The following is a description of a gene set: Acute phase response Human Gene Set: HP_ACUTE_PHASE_RESPONSE species: Homo sapiens Presence of one or more manifestations of the acute phase response. Acute phase proteins (APP) are blood proteins primarily synthesized by hepatocytes as part of the acute phase response (APR). The APR is part of the early-defense or innate immune system, which is triggered by different stimuli including trauma, infection, stress, neoplasia, and inflammation. The APR results in a complex systemic reaction with the goal of reestablishing homeostasis and promoting healing., and this is the list of marker genes: PRKAR1A, SCARB2, SPINK1, VHL, CYP27B1, RNU4ATAC, PTPN2, IFT56, LIN28B, TREX1, SEC61A1 (SEC61 translocon subunit alpha 1), GBA1, SLC34A3, AIRE, LMNA, PTPN6, TBCE, FAS, GCM2, UBA1, LACC1, PLCG1, BMP6, CCR1, TGFB1, IL6, IL2RA, MEFV, UMOD, SLC4A1, SLC7A7, LMO1, C4A, CARD10, CTLA4, ANKRD55, IRAK1, ADORA2A, FH, SLC40A1, PHOX2B, IFIH1, ADA2, SH2D1A, TMPRSS6, CP, SLC25A38, CYP24A1, CDC73, IL1R1, MAX, P4HA2, PIEZO1 (piezo type mechanosensitive ion channel component 1 (Er blood group)), STAT2, HLA-DPA1, NFKBIL1, PSMB9, IL12A, CASP10, HFE, TRAF3, RNF31, LBR, MYD88, COPA, STX16, ITK, TLR4, CTRC, LYN, TBX1, TBK1, TLR3, PDE4D, MPV17, PSMB10, PTPN22, SLC22A4, KIF1B, LPIN2, IFNGR1 (NCBI Gene Id 3459), CFTR, SAT1, SLC29A3, RET, KARS1, STXBP2, TMEM127, TNFRSF1A, UNC93B1, PTH, CDKN2C, KLRC4, HLA-DRB1, FOCAD, IL2RB (interleukin 2 receptor subunit beta), SLC19A1, KL, CD244, BCS1L, PIGA, ERAP1, CIITA, SHARPIN, ALK, PRTN3, STEAP3, SDHAF2, MIF (macrophage migration inhibitory factor), IL12A-AS1, KCNN4, NCF4, PRSS1, GNAS-AS1, MLX, MIR140, STAB1, IL36RN, STING1, OCRL, FTH1, PSTPIP1, GNAS, FTL, SDHD, CDKN2B, TFR2 (transferrin receptor 2), VDR, C1QB, ARPC5, ITGB2, AP1S3, NOD2, PRF1, HMOX1, NF1, SDHA, HBB, LYST, SYK, ARPC1B, HAMP, SPP1, CASR, MVK, FAM20A, OTULIN, IL12B, XIAP, PHEX, CLDN16, PIK3CG, NLRP12, HAVCR2, DLST, CDKN1A, POMP, PUS1, CYP2R1, UBAC2, STX11, IFNG, CMPK2, IL6ST, IL37, PSMB4, NLRP3, CDKN1B, PRG4, SLC34A1, SDHB (NCBI Gene Id 96200), MEN1, CPOX, C2orf69, CPA1, UNC13D, HJV, SAMD9, ZNFX1, SLC25A11, NLRC4, TRPV6, GLRX5, HLA-B, CLDN19, BMP2, HACE1, HLA-DPB1, PRSS2, ELF4, IL10, CD247 (NCBI Gene Id 919), IL1RN, IL23R, MDH2, NLRP1, TICAM1, PKLR (NCBI Gene Id 5313), PSMG2, SDHC, CYP3A4, MCM10, PSMB8, SOST, STAT4, DEF6, MYCN, PRKCD